Given this list of marker genes NTRK3, C1QTNF3, PTGIS, FIBIN, ADAM33, NAV3, ANGPTL6, DPYSL3, ANGPTL1, PID1, HTRA3, PRELP, WNT2B, COL12A1, RGS10, NPDC1, CRABP2, BST1, PDGFRL, NRK, OMD, PRRX1 (NCBI Gene Id 5396), MXRA5, CTSK, RASSF2, FMO1, PDLIM3, GFRA1, ITM2A, CHRDL1, EPHB2, ASPN, SPON2, IGFBP6, FLRT2, THBS3, ADAMTSL4, LINC01133, FJX1 (four-jointed box kinase 1), SERPINF1, MFAP5, DLK1, SSC5D, KDELR3, FZD4, PROS1, LOX, SCG5, TRIO, PDIA5, GXYLT2, CLEC3B, TENT5A, DNER, TNXB, THBS2, C1R, ENTPD2, ADAMTSL3, ANXA1, CPZ, CFH, RCN3, MIR503HG, SH3BP5, PI15, CD34, C1QTNF2, SCARA5, PAMR1, EMP1, here is a description of the gene set: Human Gene Set: HE_LIM_SUN_FETAL_LUNG_C0_ADVENTITIAL_FIBROBLAST studied in species Homo sapiens Adventitial fibro from publication He P, Lim K, Sun D, Pett JP, Jeng Q, Polanski K, Dong Z, Bolt L, Richardson L, Mamanova L, Dabrowska M, Wilbrey-Clark A, Madissoon E, Tuong ZK, Dann E, Suo C, Goh I, Yoshida M, Nikolić MZ, Janes SM, He X, Barker RA, Teichmann SA, Marioni JC, Meyer KB, Rawlins EL (PMID 36493756)